The following is a description of a gene set: from publication Fu W, Ergun A, Lu T, Hill JA, Haxhinasto S, Fassett MS, Gazit R, Adoro S, Glimcher L, Chan S, Kastner P, Rossi D, Collins JJ, Mathis D, Benoist C (PMID 22961053) Human Gene Set: GSE40274_CTRL_VS_XBP1_TRANSDUCED_ACTIVATED_CD4_TCELL_UP The transcription factor FoxP3 partakes dominantly in the specification and function of FoxP3+ CD4+ T regulatory cells (Tregs), but is neither strictly necessary nor sufficient to determine the characteristic Treg transcriptional signature. Computational network inference and experimental testing assessed the contribution of several other transcription factors (TFs). Enforced expression of Helios or Xbp1 elicited specific signatures, but Eos, Irf4, Satb1, Lef1 and Gata1 elicited exactly the same outcome, synergizing with FoxP3 to activate most of the Treg signature, including key TFs, and enhancing FoxP3 occupancy at its genomic targets. Conversely, the Treg signature was robust to inactivation of any single cofactor. A redundant genetic switch thus locks-in the Treg phenotype, a model which accounts for several aspects of Treg physiology, differentiation and stability. studied in species Homo sapiens Genes up-regulated in CD4 T conv: control versus over-expression of XBP1., and this is the list of marker genes: CRYBG1, IFIT3 (interferon induced protein with tetratricopeptide repeats 3), STARD5, PIP4K2A, PPP3CC, FES, IFT140, DPP4, S100A4, GGTA1, ORMDL1, TLR3, PICALM, ARID5A, TMEM59, PITPNC1, SP100, UBL3, PSEN1, TLN1, ATP2A3, NOTCH2, NKG7, MICAL1, PDE5A, SOCS3, HCAR2, RHOG, CALCRL, GNG2, KYNU, MYL12B (NCBI Gene Id 103910), ZFP3, AHNAK, RTL5, APOBEC1, PLEC (NCBI Gene Id 5339), IKZF3, PTP4A3, TCF7, BFSP2, RAB31, CEBPA, YPEL5, RFLNB, ANTXR2, RASGRP1, STXBP2, MYO10, GRK2, SLAMF1 (signaling lymphocytic activation molecule family member 1), SPIC, GIMAP4, SLC25A45, FRMD4A, FCRL5, LRG1, TERC, FMNL3, PIK3C2B, FMN1, HPSE, RNF167 (ring finger protein 167), SLC12A7, C2, PRKD2, ANXA6, CSF3R, ROGDI, NMI, CDC25B, UTRN, RNF13, RWDD2A, MPZL1, IL2RB, MAST4, PPBP, EDEM2, STK10, IRF7, CD28, FAM193B, BBS9, CDH5, KIF21B, SPO11, THEMIS2, KCTD12, SLC4A11, EGLN2 (NCBI Gene Id 54750), AGAP1, ALOX5, XKRX, ENPP4, NDST1, RIN2, CTBP2, SGIP1, N4BP2L1, PTGR3, PFKFB4, PHF21A, ITGAD, ST6GAL1, PLAUR, RIGI, SMAD4, CPEB2, PREX1, CD33, ITSN2, EFCAB9, USP25, IL18, SENP7, PXK, PSD4, GPR155, GIMAP3P, PSAP, DMPK, FCGRT, IL10RA, ARL6IP1, ATF7IP, CTSH, ZNF18, HELZ2, PIGV, LRP5, FBXO32, MLX, PPP6R2, PTCHD1, NAA60, CCL5, HES1, CBX8, FCRL1, GLCCI1, MS4A14, SCEL, RAC3 (Rac family small GTPase 3), SLC2A3 (NCBI Gene Id 94827), SERPINB8, MET, CYRIA, CYB5A, TNFAIP2, ST3GAL1 (ST3 beta-galactoside alpha-2,3-sialyltransferase 1), EHD3, CASP6, ARRB1, ZEB2, ICOS, ENPP1, CHST15, LRRK2, CYSLTR1 (NCBI Gene Id 10800), MAP3K8, LRRC61, SLC15A4, RASSF4, LDLRAD3, ABI1, EMID1, ACVRL1, TLR2, UBE2E2, KLHL6